The following is a description of a gene set: Mouse Gene Set: HUMMERICH_MALIGNANT_SKIN_TUMOR_UP Genes up-regulated in malignant skin tumors (squamous cell carcinoma, SCC) formed by treatment with DMBA and TPA in the two stage skin carcinogenesis model. from publication Hummerich L, Müller R, Hess J, Kokocinski F, Hahn M, Fürstenberger G, Mauch C, Lichter P, Angel P (PMID 16247483) studied in species Mus musculus Chemically induced mouse skin carcinogenesis represents the most extensively utilized animal model to unravel the multistage nature of tumour development and to design novel therapeutic concepts of human epithelial neoplasia. We combined this tumour model with comprehensive gene expression analysis and could identify a large set of novel tumour-associated genes that have not been associated with epithelial skin cancer development yet. Expression data of selected genes were confirmed by semiquantitative and quantitative RT-PCR as well as in situ hybridization and immunofluorescence analysis on mouse tumour sections. Enhanced expression of genes identified in our screen was also demonstrated in mouse keratinocyte cell lines that form tumours in vivo. Self-organizing map clustering was performed to identify different kinetics of gene expression and coregulation during skin cancer progression. Detailed analysis of differential expressed genes according to their functional annotation confirmed the involvement of several biological processes, such as regulation of cell cycle, apoptosis, extracellular proteolysis and cell adhesion, during skin malignancy. Finally, we detected high transcript levels of ANXA1, LCN2 and S100A8 as well as reduced levels for NDR2 protein in human skin tumour specimens demonstrating that tumour-associated genes identified in the chemically induced tumour model might be of great relevance for the understanding of human epithelial malignancies as well., and this is the list of marker genes: S100a9, Hba-a1, Sprr2d, Cotl1, Col1a2, Ccnd1 (cyclin D1), Krt13, S100a8, Col18a1, Krt16, Ltf, Slpi, Gsta4, Fam110d, Saa3, Plet1, Gsto1, Ecm1, Rhog